Given this list of marker genes Il1r2, Matn4, 2810002D19Rik, Per2, Hmg20a (high mobility group 20A), Uhrf1, Larp6, Dbp, Per3, Spaca7b, Ngef, Mmp10, Tcte2, Septin8, Mlf1 (myeloid leukemia factor 1), Med19 (NCBI Gene Id 73177), Fam110a, Creb1, Tuba3b, Cd93, Rnf20, Syt11, Rtn4r, Pdlim5, Agpat5, Icosl, Wee1, Pla2g4f, Tef, Trim24, Usp12, Prcp, Aplnr (NCBI Gene Id 23796), Ncan (NCBI Gene Id 270055), Bambi, Sptlc2, Socs3, Rab33a, Igkv4-72, Krtap6-1, Elk4, Dusp7, Cenpk, Taf1d, Ptpn21, Sike1, Hdac7, Lipt2, Mknk2, Rab27b, Ect2, Pitpnm1, Usp2, Rrm2, Kcnk10, Tbc1d15, Lepr, Nfatc4, Usp9x (NCBI Gene Id 77016), here is a description of the gene set: The molecular pathogenesis and the genetic aberrations that lead to the progression of hepatocellular carcinoma (HCC) are largely unknown. Here, we demonstrate that the thioredoxin interacting protein (Txnip) gene is a candidate tumor suppressor gene in vivo. We previously showed that the recombinant inbred congenic strain HcB-19 has a spontaneous mutation of the Txnip gene, and we now show that the strain has dramatically increased incidence of HCC, and that the HCC cosegregates with the Txnip mutation. Approximately 40% of the Txnip-deficient mice developed hepatic tumors with an increased prevalence in male mice. Visible tumors develop as early as 8 months of age. Histological analysis confirmed the morphology of HCC in the Txnip-deficient mice. Molecular markers of HCC, alpha-fetoprotein and p53, were increased in tumors of Txnip-deficient mice. The upregulation of p53 preceded tumor development; however, bromodeoxyuridine (BrdU) labeling of normal hepatic tissue of Txnip-deficient mice did not reveal increased cell proliferation. Finally, microarray analyses of tumor, non-tumor adjacent, and normal tissue of Txnip-deficient mice highlighted the genetic differences leading to the predisposition and onset of HCC. Our findings suggest that Txnip deficiency is sufficient to initiate HCC and suggest novel mechanisms in hepatocarcinogenesis. studied in species Mus musculus Mouse Gene Set: SHETH_LIVER_CANCER_VS_TXNIP_LOSS_PAM6 Cluster PAM6: genes changed exclusively in normal liver tissue adjacent to hepatocellular carcinoma (HCC) from mice deficient for TXNIP. from publication Sheth SS, Bodnar JS, Ghazalpour A, Thipphavong CK, Tsutsumi S, Tward AD, Demant P, Kodama T, Aburatani H, Lusis AJ (PMID 16607285)